The following is a description of a gene set: Mouse Gene Set: GOBP_PURINE_RIBONUCLEOSIDE_METABOLIC_PROCESS species: Mus musculus The chemical reactions and pathways involving any ribonucleoside, a nucleoside in which purine base is linked to a ribose (beta-D-ribofuranose) molecule., and this is the list of marker genes: Gamt, Hprt1, Ptgdr, Mtap, Nt5c2, Pcmt1, Acp3, Adk, Nt5c1b (NCBI Gene Id 70881), Aprt, Urah, Ahcy, Icmt, Nt5c1a, Ahcyl, Pnp, Pgm2, Pemt, Bloc1s6, Nt5c3, Gnmt, Uox, Xdh, Enpp4, Ada, Urad, Ak1, Nt5e, Adal, Pnp2